Given this list of marker genes NCOA7, PEX14, PRKN, CRYGD, MAPK13, ARL6IP5, LRRK2, HTRA2, PLA2R1, TXN, BECN1, AMBP, ZC3H12A, FANCC, FER, SIN3A, STX2, CAT, MIR132, RIPK1, MAPKAP1, FOXO3 (NCBI Gene Id 2309), MAP2K4, MDM2, CUL3, PPIA, PEX10, MAP3K5, SUMO4, UCP1, DDR2, PYCR2 (NCBI Gene Id 29920), SLC4A11, NOS3, WNT16, STAU2 (staufen double-stranded RNA binding protein 2), STK24, ERCC6L2, PPIF, ATP7A, MGAT3, SLC7A11, ATF2, PARP1 (poly(ADP-ribose) polymerase 1), VKORC1L1, PENK (proenkephalin), PRDX5, ZNF580, GPX5, MGST1, ATF4, PRKD1, GPX7, FANCD2, EZH2, ZNF277, MIR21 (NCBI Gene Id 406991), ATP13A2, VRK2, PNPLA8, TOP2B, IL18RAP, STAU1 (staufen double-stranded RNA binding protein 1), CDK1, TP53INP1, NFE2L1, SOD2, MAPK9, SNCA, OGG1, RWDD1, BMP7, MIR135A1, RELA, RPS3, CBX8, SLC25A24, AIFM1, RACK1, SOD3, MIR17, CAMKK2, HDAC2, PEX13, ADPRS, BNIP3, MAPT, ROMO1 (reactive oxygen species modulator 1), DHFRP1, DHFR, GPR37L1, ABCD1, PLEKHA1, TRPM2, FXN, PRKCD, CD36 (NCBI Gene Id 948), PDCD10, ABCC1, TPM1, FBLN5, FOXP1 (forkhead box P1), AIF1, MPV17, PJVK, PML, PEX2, HIF1A, SLC25A14, RHOB, PDK2, MAPK7, MT3, PPARGC1A, CYGB, FABP1, CYP1B1, PDGFRA (NCBI Gene Id 5156), NME8, MIR103A1, G6PD, SIRPA, ANKZF1, SRXN1, HSPA1A, CCS, RAD52, RBX1, PCNA, NET1 (NCBI Gene Id 10276), AQP1, TRPA1, KAT2B, KDM6B, OSER1, PRKAA1, EDN1, PYROXD1, TMEM161A, TREX1, FBXO31, AIFM2, PPEF2, GPX1, PCGF2, TRPC6, ZFAND1, SLC11A2, APOA4, FOXO1, PYCR1, MB (NCBI Gene Id 4151), PNPT1, MEAK7, TP53, GATA5, HSF1, FOS, STK25, HM13, PDGFD, CFL1, PEX5, MIR107, HDAC6, MMP3, EDNRA, ATP2A2, GPR37, PKD2, PXN, SOD1, BRF2, SPHK1, SESN2, SIRT1, SRC, RIPK3, ETV5, NAGLU, ARNT, PRDX1, BMAL1, PARK7, KLF4 (KLF transcription factor 4), MYB, PRDX2, GCH1, MIR92A1, PAWR, GPX8, ABL2, PRKRA, ALDH3B1, PINK1, AKT1, STX4, FUT8, TMIGD1, DHRS2, SMPD3, NQO1, MAP1LC3A, AGAP3, PPP5C, FADS2, ENDOG, MAPK8, TNFAIP3, ERN1, KEAP1, XBP1, SLC8A1, MET, BTK, SLC1A1, NPPA, STK26, IL6, SELENON, LONP1, NFE2L2 (NFE2 like bZIP transcription factor 2), PRDX3, SELENOS, TRAP1, GSR (glutathione-disulfide reductase), CDKN2A, KLF2, DAPK1, FYN, HGF, ERMP1, MIRLET7B, IL18BP, MSRA, MMP2, ECT2 (epithelial cell transforming 2), PRKAA2, ATM, SETX, PRR5L, TET1, HSPA1B (heat shock protein family A (Hsp70) member 1B), EIF2S1, OXR1, PTPRK, MIR34A, NR4A2, CHCHD2, LCN2, PEX12, RBM11 (NCBI Gene Id 54033), SIRT2, ABL1, ALOX5, NUDT2, TBC1D24, MPO, MIR133A1, here is a description of the gene set: studied in species Homo sapiens Human Gene Set: GOBP_CELLULAR_RESPONSE_TO_OXIDATIVE_STRESS Any process that results in a change in state or activity of a cell (in terms of movement, secretion, enzyme production, gene expression, etc.) as a result of oxidative stress, a state often resulting from exposure to high levels of reactive oxygen species, e.g. superoxide anions, hydrogen peroxide (H2O2), and hydroxyl radicals.